Given this list of marker genes SERPINB9P1, LINC01093, UBTD2, TRAF3IP2, PCBP1-AS1, SMAD3, PCGF3-AS1, MT1HL1, BCL6, FCGR2A, SGPP2, EBF1, TMEM184B, ACOD1, HS3ST3B1, PIM2 (NCBI Gene Id 11040), CNN2, ATP13A3-DT, ANKRD33B, ZNF710 (zinc finger protein 710), ZNF835 (zinc finger protein 835), FPR1, PFKFB3, ADM, SQSTM1, APOBEC3A, IL6, ORM1, ADAM33, USF2, GNG2, MDM2, CXCL2, HSPA1A, IL1B, SLAMF7, MT1F, ST3GAL2, LILRB2, IFT57, PTPRJ, HSPA13, SND1-IT1 (NCBI Gene Id 92498), SLITRK2, IFI6, TCF7L2, SCN1B, ZCCHC2, ATP6V1C1, CHI3L1, MSANTD3, OTUD5, HNRNPC, OSM, HK2, MSN, ADGRE1, INSIG1, PLAGL2, ARHGEF2, RETN, CEBPD, S100A8, HERC5, TNIP3, SH3D21, SKIL, DENND5A, SLC43A3, THBS1, UPB1, RUBCNL, MAEA, SMS (spermine synthase), PRKCH, NFKBIZ, ABCA1, PTK2B, SOD2, ZMIZ1, SOCS3, MAML2, RESF1, GJB2, IRS2, MARCKS, LYN, FOSL2, SGTB, PIAS1, PTGER4, NSMAF, PLPP3, RAP1B, PROK2, ERBIN, LPCAT1, DUSP16, C15orf48, MAP3K8, EIF2AK2, PLAU, PRKAG2-AS2, SLC7A7, CHST15, PPP1R12A, ADAMDEC1, CD48, SLFN5, RNF144B, PTX3, RSAD2, PLXND1, MT1H, SMG7 (SMG7 nonsense mediated mRNA decay factor), SNAPC1, GPR132, MXD1, NCF4, ZFP36L1, PNRC1, HSPA6, MAFB, LCP1 (lymphocyte cytosolic protein 1), ATP13A3, PRKAG2, BTG1, ANKRD36, LINC-PINT, ETV5, VEGFA, NBR1, IRAK3, DPH3P1, MAP4K4, SLC16A7, AQP9, ATP2B1, TNFSF9, MT1G, FNDC3B (fibronectin type III domain containing 3B), TNFRSF8, RCAN1, CD22, SLC22A6, NT5C3A (5'-nucleotidase, cytosolic IIIA), SLC11A2, SLAMF1, STAT5A, MFSD2A, GHRL, TNFAIP3, CFB, FMNL3, CXCL3, TNFSF14, AFTPH, MYBPH, PTGES, NEURL3, TAB2, KRTAP4-1, RASSF2, RAB13, VNN2, CCL20, VPS13D, STAT5B, QPCT, BMF, CHST7, IL36G, GRAMD1A, VNN3P, VNN1, SAMSN1, TCFL5, DSE, SLC6A6, SLC35A2, CEMIP, FPR2, LIMS1, CNEP1R1, LCN2, RGS2, NOTCH2NLA, AMPD3, CCM2L, RHOV, OASL, NIBAN1, IFI44, CELF1, SLC39A8, ABCA7 (NCBI Gene Id 82843), IL1R1, CASP5, IFITM2, here is a description of the gene set: species: Homo sapiens from publication Szanto A, Balint BL, Nagy ZS, Barta E, Dezso B, Pap A, Szeles L, Poliska S, Oros M, Evans RM, Barak Y, Schwabe J, Nagy L (PMID 21093321) Conditional macrophage-specific PPARg knockout mice were generated on C57Bl/6 background by breeding PPARg fl/- (one allele is floxed, the other is null) and lysozyme Cre transgenic mice. PPARg and IL-4 signaling was analyzed on bone marrow-derived macrophages. Bone marrow of 3 mice per group was isolated and differentiated to macrophages with M-CSF (20 ng/ml). 20 ng/ml IL-4 was used to induce alternative macrophage activation and 1 uM Rosiglitazone (RSG) was used to activate PPARg. From each mouse 4 samples were generated: 1. M-CSF, 2. M-CSF+RSG, 3. IL-4 and 4. IL-4+RSG. All compounds were added throughout the whole differentiation process, and fresh media was added every other day. Control cells were treated with vehicle (DMSO:ethanol). After 10 days, RNA was isolated and gene expression profiles were analyzed using Mouse Genome 430 2.0 microarrays from Affymetrix. Genes up-regulated in bone marrow-derived macrophages: wildtype versus PPARG knockout. Human Gene Set: GSE25123_WT_VS_PPARG_KO_MACROPHAGE_UP